Given this list of marker genes IGF1, RECK, CD27, IL7R, CD72, POLR1B, ATXN10, HDAC7, H1-0, SNHG6, MGP (matrix Gla protein), TAF9, SCD, FRAT2 (FRAT regulator of WNT signaling pathway 2), ZNF821, KIAA2013, DDAH2, SH3BGR, OLFM1, METTL9, MR1, DTD1, C1R, CD2, PEX7, RNF11, NAT8 (NCBI Gene Id 9027), TSPAN13, MEF2C, ENO1, TXNDC17, CD5, SPIC, EXT2, C4orf3 (chromosome 4 open reading frame 3, NCBI Gene Id 401152), LPCAT1, EIF3E, HS3ST1, SPATA13, TRBC1, RNASE3, POU2AF1, ANKRD10, UBE2B, TRAF4, USP18, DCK, GUCA2B, GAPDH, CAMK2D, HINT2, TM2D2, CD8A, EPX, DLAT, CD83, ARMCX2, F2R, MIGA2, MS4A1, LEF1, RNF220, LTF, POLM, PLET1, ZCCHC3, SMAGP, MYO1D, ZNF362, GSTA2, SMO, GSDME, HK2, PKP4, PGM1, CYP7B1, HIVEP2, PCCB, RAB31, MCOLN2, POSTN, ACOT9, LY6D (NCBI Gene Id 8581), TNFRSF19, SLC12A2, LHPP, PTGER4, MARCKS, LGALS3BP, RAMP1, XPO1, MOCOS, BMAL1, PHTF2, RMC1, TMEM205, ZFP2, PLBD1, IFNB1, AKT1, HOXA7 (NCBI Gene Id 3204), CXCR5, CBX6 (NCBI Gene Id 23466), CLDN1, PDCD6, TFB2M, DMPK, CDC42EP4, FCRLA, FYN, PDZK1, SLC25A53, DDR1, MYL4, FCER2, ANXA1, PAN2, IL1RL1 (NCBI Gene Id 9173), HSPA4, DSP, LIMS1, ALDH7A1, PSIP1, RSL24D1, CCNG2, NFE2L2, RGS9, ANG, PSMD9, DUSP9, CYP11A1, ELN, CD3E, CYP2S1, HNRNPA2B1, IFI27L2, PYHIN1, IARS2, NAGLU, ENPEP, F10, LHX3, ELL2, KLK1, ST6GALNAC4, HDC, MMP9, ZDHHC14, ATP1B3, PRDM5, IFIT1B, CIDEB, VPS53, EOMES, PPIC (peptidylprolyl isomerase C), CD6, GUCD1, VPREB1, IL4, MEIS1, CD79A, BLNK, PES1, IGLV4-69, KRTAP5-2, FKBP9, CEBPZ, CD5L, ITK, REXO5, VPS41, WFDC21P, DNTT, PDK1, CD55, SRGAP2, RAP1A, RB1, TPI1, TTC39B, HOXA10, IFIT2, GAS2, AKAP8, CD8B, C15orf39, KANK3, PDXDC1, LSG1, MTDH, LYSMD2, ELOVL5, HOXA9, ODC1, PLA2G7, GOLIM4, CLN6, INHBA, ARG2, CLCN3, RYR1, PENK, FERMT3, TAF1B, TGIF2, THY1, IRF4, CMBL, CD19, GPX3, AQP9, PRKCA (NCBI Gene Id 5578), NFIX, SLC30A4, DNAJC3, ALOX15, DSC1, PDLIM1, CYRIB, DAB2IP, BPNT2, HPS1, RBPMS, IL1RN, CHCHD10, CXXC5, SFMBT2, ABLIM1, TRBC2, IFIT3, ICA1, PTCH1, UPP1, CITED2, OGFOD2, CYP2A6, COX6A2, SHD, EYA2, TCF7, HMGCS1, ZAP70, BLK, CPSF4, ZIK1, NME3, ST6GAL1, GZMA, LCT, TRIM5, LCK, PGRMC2, KLRD1, PML, CD9, GNG12, STK39, PAX5, ACOD1, CORO2B, COL19A1, ARL6IP4 (ADP ribosylation factor like GTPase 6 interacting protein 4), FASN, CPA3, GIMAP4, IGHD (NCBI Gene Id 3495), SH3GLB1, ATM, RHOB, SPIB, GPC4, LGR5, EPHX1, VTA1, IGLC1, MS4A2, KMT2A, CSNK1A1, TRAC, CEACAM1, KMT5A, RSAD2, SERPINB3, RALGPS2, SEMA6B, MRC1, FCER1A, NAV1, PDE7A, PRG2, ABHD8, SIT1, CMTR1, CDIP1, CTSW, ATG7, TERT, TMEM141, SLAIN1, ZFPM1, EIF3J, ACADS, HOXA5, GABBR1, MBNL1, CTSB, TMEM183A, VNN3P, CTC1, RAG1, PRG3, CYP2D6, PCBP2, ADGRG3, FCGR1A, PIM2, RBBP6, GSTO1 (NCBI Gene Id 9446), GNB4, IGHM, FBP1 (NCBI Gene Id 2203), ABCC5, HMX3, SLC31A1, IRF9, GALNT3, IRGM, MAG, NCR1, ISG15, TP53INP2, ANGPT1, CCL5, GIMAP1, REM1, RUSC1, SPTLC2, MID1IP1, B4GALNT1, SPATA6, NABP1, NSG2, GDPD3, EXTL3, KLRC1, GATA3, HPGD, ITM2A, CDH5, NPEPL1, CMPK2, CAPRIN2 (NCBI Gene Id 84116), VCAM1, ORMDL3, PTPRCAP, CIB1, CXCR3, EBF1, IDH1, PRKCQ, GUSB, CTSC, ABHD14A, ITSN1, GJB3, GTPBP2, EIF2S2, ZFTRAF1 (zinc finger TRAF-type containing 1), RABGGTB, PTP4A3, CCR9, IGLL5, GLG1, CYB561, MAPK3, ADAR, BCKDHA, HOXA6, SOX4, PERP, ICOS, RPS6KB2, STX18, PFKP, TMEM30A, F2RL2, UGDH, TXN, LTB, PLS3, GPC1, PLA2G4A, OLA1, TBXAS1, SDC4, IGHV1-2, F8A1, USE1, KCNAB2 (NCBI Gene Id 8514), SATB1, C1QC, BASP1, SPP1, OTUD5, RPS6KC1, FAM76B, here is a description of the gene set: Identification of the targets of mixed lineage leukemia (MLL) fusion genes will assist in understanding the biology of MLL fusion gene leukemias and in development of better therapies. Numerous studies have implicated HOXA9 as one of the possible targets of MLL fusion proteins. To determine if HOXA9 was required for leukemia development by MLL fusion genes, we compared the effects of the Mll-AF9 knock-in mutation in mice in the presence or absence of Hoxa9. Both groups of mice showed myeloid expansion at 8 weeks and then developed myeloid leukemia with a similar incidence and time course. The leukemia in the mice lacking Hoxa9 generally displayed a more immature myeloid phenotype than that in the mice that were wild-type for Hoxa9. Gene expression profiling revealed that expression of Mll-AF9 led to overexpression of Hoxa5, Hoxa6, Hoxa7, Hoxa9, and Hoxa10. Thus, genes of the Hox-a cluster are important in defining the phenotype but not the incidence of Mll-AF9 leukemia. These results demonstrate that the Mll-AF9 fusion gene disrupts the expression of several Hox genes, none of which as a single gene is likely to be necessary for development of leukemia. Instead, we propose that the Hox code minimally defined by the Hoxa5-a9 cluster is central to MLL leukemogenesis. Myeloid leukemia model in mice with germ-line MLL-AF9 fusion knock-in: genes changed in comparison among the leukemic, preleukemic and wild-type animals. Human Gene Set: KUMAR_TARGETS_OF_MLL_AF9_FUSION from publication Kumar AR, Hudson WA, Chen W, Nishiuchi R, Yao Q, Kersey JH (PMID 14615372) species: Mus musculus